The following is a description of a gene set: The process in which relatively unspecialized cells acquire specialized structural and/or functional features that characterize the mature cells of the hindbrain. Differentiation includes the processes involved in commitment of a cell to a specific fate. Mouse Gene Set: GOBP_CELL_DIFFERENTIATION_IN_HINDBRAIN species: Mus musculus, and this is the list of marker genes: Mtpn, Lhx1, Nrxn1, Foxp2 (NCBI Gene Id 72715), Atxn2, Nfix, Cbln1, Gata2, Grid2, Cend1, Psap, Skor2, Ttc21b, Wnt7a, Herc1, Faim2, Ldb1, Rora, Slc25a46, Ophn1, Lhx5, Cacna1a, Foxa2, Ttll1, Atp7a, Nog, Ulk1, Agtpbp1, Atp2b2, Phox2b, Kndc1, Prox1